The following is a description of a gene set: The process whose specific outcome is the progression of an epithelium in the kidney over time, from its formation to the mature structure. An epithelium is a tissue that covers the internal or external surfaces of an anatomical structure. Mouse Gene Set: GOBP_KIDNEY_EPITHELIUM_DEVELOPMENT species: Mus musculus, and this is the list of marker genes: Wnt11, Ptpro, Tmem59l, Wt1, Cd34, Agtr1b, Slc22a6, Mir217, Lhx1, Gsta3, Timeless, Ctnnb1, Efnb2, Stat1, Fgf2, Sfrp1 (secreted frizzled-related protein 1), Sox9, Cd44, Pgf, Mir216b, Ednrb, Yap1, Wnt7b, Hes1, Gdf6, Pdgfb, Nog, Ret, Adipoq (adiponectin, C1Q and collagen domain containing), Cer1 (cerberus 1, DAN family BMP antagonist), Irx3, Calb1, Six2, Hnf1b, Lamb2, Ilk, Agtr2, Tcf21, Foxc2, Mir216a, Podxl, Lzts2, Smad6, Gdf11, Gzf1, Nphs2, Cat, Pspn, Npnt, Klhl3, Hoxd11, Sdc4, Acat1, Smo, Wwtr1, Bmp4, Foxc1, Lif, Ampd2, Pax2, Irx2, Wnt2b, Bmp2, Ednra, Crlf1, Wnt9b, Bcl2, Robo2, Grem1, Epcam, Vegfa, Ext1, Magi2, Cited1, Pkd2, Cxcr2, Gata3, Bdnf, Asxl1, Notch1, Ctns, Commd5, Foxj1, Irx1, Six4, Greb1l, Vcan, Tacstd2, Spry1, Shh, Jag1, Hey1, Wnk4, Myo1e, Hs2st1, Sox8, Epha4, Fmn1, Bmp7, Sdc1, Wnt6, Ctnnbip1, Smad5, Fgfr1, Bmper, Maged1, Rarb, Dlg1, Myc, Adamts16, Slit2, Edn1, Pou3f3, Eya1 (EYA transcriptional coactivator and phosphatase 1), Smad7, Wnt1, Osr1, Kif26b, Mtss1, Hs3st3b1, Agt, Fgf1, Smad9, Wnt4, Epha7, Six1, Pkd1, Hes5, Tfap2b, Kank2, Dchs1, Pbx1, Klf15, Smad4, Abcc2, Tgfb1, Foxd1, Cd24a, Aqp11, Hoxb7, Gli3, Arg2, Fat4, Nphs1, Sall1, Lgr4, Slc22a1, Aqp1, Prom1, Dspp, Notch2, Hs3st3a1, Basp1, Smad2, Tshz3, Ptch1, Gdnf, Gpc3, Dll1, Iqgap1, Mef2c, Cited2, Fgf8, Hoxa11, Smad3, Cd2ap, Agtr1a, Smad1, Umod, Lama5, Sim1, Fgfr2, Rara, Heyl, Pax8